The following is a description of a gene set: Genes predicted to be targets of miRBase v22 microRNA hsa-miR-498-3p in miRDB v6.0 with MirTarget v4 prediction scores > 80 (high confidence targets). species: Homo sapiens from publication Chen Y, Wang X (PMID 31504780) Human Gene Set: MIR498_3P, and this is the list of marker genes: TDG, ADAMTS17 (NCBI Gene Id 170691), CPSF7 (NCBI Gene Id 79869), MOB1A, INSIG1, NIPSNAP3A, PRKAB2, PIK3R1, EMP2, SYN2, PPP1R15B, CDK6, AKAP13, ASCL4 (achaete-scute family bHLH transcription factor 4), OPN3, SLC2A14, RAP1A, ACBD5, PCSK5, SEMA4D, GSE1, ADSL, DENND1B, ZBTB41, NID1, ASXL3, MORF4L2, MED12L, CNR1, LDLRAD4, COL9A1, PTPRK, VPS37C, BNC2, ADO, TRA2B, ERC1, THBS2, PDGFB, SFXN3, CNTN1, CREB5, SOWAHC, TAF5, HOMER2, SERINC5 (serine incorporator 5), DCX, ZCCHC14, N4BP2 (NCBI Gene Id 55728), LRP6, JOSD1, NAV2, DOCK3, SLC2A3, RAB12, CCNYL1, USP34, LOXL4, GLIS3, RCC2, TRIM63, CCDC138, PTBP3, TMEM65, PER3, KLHL18, ALKBH8, ASPH, SCN2A, CTSO, CGGBP1, BIRC2, OSTC, CEP152, PPP2R5D, EPHA7, SYPL2, MFAP1, GPAM, AMOT, PTX3, PUS7, GNE, TENM3, USP42, NAV1, XKR4, ZNF438, CCNY (NCBI Gene Id 219771), RFX3, UBFD1 (ubiquitin family domain containing 1), ADAM19, C5orf15, DOLPP1, LIMS1, DAB2, FAM3C, RND3, MORF4L1 (mortality factor 4 like 1), DCLK1 (doublecortin like kinase 1), RARB, PRKRA, NSF, MXD1, ATP2B1, CHFR, CLK2, SCN9A, PAIP2 (NCBI Gene Id 51247), HS2ST1, TET3, TMEM74, SMS, EFEMP1, HAS3, ATP2B4, RELA, PDGFA, TIPRL, CDKL5, SPATA2L, PROSER1, CYBRD1, REV3L, IGSF3, MYCN, FRS2, XKR6, TTC9, LARP4B, ZNF366, NCBP3, GRIA3 (NCBI Gene Id 2892), RAB33B, FAM13B, VASH2, MACIR, TRIB2, MIDEAS, GPX7 (glutathione peroxidase 7), PRSS12, PPIP5K2, PURG, DNMT3A, RAB14, ABHD18, TRAK2, NLRX1, COL4A4, KCTD20, ADAMTS16, GRAMD1B, SPDL1, CEP68, BRWD3, SPTAN1, CARD18, HMGN3, CCDC117, OSBPL6, GLI2, LIF, SHPRH, XBP1, N4BP2L1, KPNA1, SLC4A7, GSK3B, MAPRE2, GARRE1, PPM1E, KCNK10, TET1, SMAD2, FZD6 (NCBI Gene Id 8323), CARMIL1, COL4A2, USF3, ABHD4, SERP1, KLF4, MUC7, REST, USP6NL, AMER1, CRISPLD1, SPAST, HDAC4, PINX1, NKRF, C1orf52, VTA1, COL5A1, HDC, SOCS7, CILP2, NIN, MED28, NOTCH2, FBN1, TCF4, CAMSAP2, MACROH2A2, HACD1, PHACTR2, ARSF, HMCN1, PGAP1, FBN2, ZNF518B, EOMES, ARPP19, KCNN3, SEPHS1, BMPR1A, ABCE1, DOCK11